The following is a description of a gene set: species: Homo sapiens Human Gene Set: GOBP_PROTEIN_CATABOLIC_PROCESS_IN_THE_VACUOLE The chemical reactions and pathways resulting in the breakdown of a protein in the vacuole, usually by the action of vacuolar proteases., and this is the list of marker genes: CLN3, TMEM106B, LRP1, VPS13A, TMEM199, CPA2, SLC17A9, GBA1, VPS35, LAPTM4B, CST7, DPP7, MARCHF2, LDLR, ATP13A2, MFSD8, LRP2, LAMP2, GRN, AP5Z1, CTSH, GGA3, CCDC115, USP8, CD81, RNF128, MGAT3, TCIRG1, TPP1